Given this list of marker genes Mettl14, Tent4b, Traf2, Angel2, Secisbp2, Naf1, Igf2bp2, Tob1, Vip, Fam76b, Csde1, Gdnf, Fus, Elavl4, Vegfa, Nbas, Rbm24, Thrap3, Zfp36, Ptbp1, Igf2bp1, Nrde2, Ybx2, Taf15 (NCBI Gene Id 70439), Noct, Nsun2, Nicol1, Tent4a (NCBI Gene Id 210106), Rbm38, Paip1, Dkc1, Ikbke, Qki, Larp1, Hnrnpa0, Parn, Hnrnpd, Tent5b, Traf3ip2 (NCBI Gene Id 103213), Hnf4aos, Boll, Ybx1, Eif4enif1, Mettl16, Phax, Lrpprc, Arid5a, Fxr1, Traf5 (TNF receptor-associated factor 5), Sgms1os1, Rbm46, Elavl1, Slirp, Tent5a, Pkp3, Hnrnpu, Slc11a1, Dazl, Mettl1, Dhx36, Tardbp, Ago2, Tent2, Slfn2, Upf3a, Dhx9, Dicer1, Rbm10, Tent5c, Axin2, Pkp1, Igf2bp3, Rbm47, Trdmt1, Zar1, A1cf, Zc3h14, Syncrip, Dhx34, Mtor, E2f1, Dnd1, Mapkapk2, Meioc, Apobec1, Tent5d, Larp4b, Zcchc17, Hnrnpc, Hnrnpab, Il17a, Srsf1, Tnf, Tirap, Cirbp, Pabpc1, Mir466l, Myd88, here is a description of the gene set: Mouse Gene Set: GOBP_NEGATIVE_REGULATION_OF_RNA_CATABOLIC_PROCESS species: Mus musculus Any process that stops, prevents or reduces the frequency, rate or extent of RNA catabolic process.